The following is a description of a gene set: studied in species Homo sapiens from publication Wirth TC, Xue HH, Rai D, Sabel JT, Bair T, Harty JT, Badovinac VP (PMID 20619696) The transcriptome of naive OT-I T cells was compared to memory CD8 T cells after 1, 2, 3, or 4 infection with ovalbumin expressing Listeria monocytogenes (LM-OVA). Human Gene Set: GSE21360_PRIMARY_VS_QUATERNARY_MEMORY_CD8_TCELL_DN Genes down-regulated in memory CD8 T cells: 1' versus 4'., and this is the list of marker genes: DHRS1, TLE5, MORF4L1 (NCBI Gene Id 10933), BAHD1, BCL11B, ABLIM1, JADE2, SQSTM1, ERBIN, PIK3CA, IRF7, SERINC3, DCAF8, CCDC93, S100A10, ARL2BP, RPL37, IKBKB, ZNF83 (zinc finger protein 83, NCBI Gene Id 90328), LRP10, DOCK9, RSBN1, SNX3, BMAL1, TRIM14, SIRT3, ZNF14, CD96, SLC35E2A, CEP350, SNX6 (NCBI Gene Id 58533), NPFF, NDRG1, SENP6, PARP8, CCDC91, ARFGEF1, SORL1, KLF2, BAZ2A, BNIP3L, ALAD, STAG2, PPP6R3, MON2 (MON2 homolog, regulator of endosome-to-Golgi trafficking), RPS15A, TOP2B, SON, FAM149B1, CAPN2, SLC16A5, ATF2, WASF2, ENTPD4, OSBPL2, PRKCQ, BACH1, USPL1, LRCH4, SAMD9, ZNF862 (zinc finger protein 862), PNRC1, FAM117A, TAX1BP3, NCOR1, UBL3, PRKCZ, RIN3, FBXL5, EFCAB14, SYNJ2BP, ASAH1, S100A6, ST6GAL1, SMURF2, SSH3, PCF11 (NCBI Gene Id 51585), GALNT11, MST1, RC3H2, HSD17B3, RAB4B, TMEM63A, LIPT1, ARMC8, ASTE1, PLEKHO1, EPM2AIP1, MACF1, MZF1, ULK1, ZNF573, HPCAL4, CLCC1, DENND2D (NCBI Gene Id 79961), WDR44, VPS13B (vacuolar protein sorting 13 homolog B), SKAP1, ZFYVE16, KDM5A, TMED10, ATP6AP2, IFI44L, ZNF236, RBM26, TNK2, ZFAND6, TTC17, ZBED5, RXRB, USP11, C2orf68, GPRASP1, CCS, NME3, NGRN, ELANE, HIPK1 (homeodomain interacting protein kinase 1), TOR1B, ZC3H11A, STAT4, WDR45, CTBS, RASGRP1, CTDSP2, C6orf62, AGTPBP1, ZNF652, PSME3IP1, TDRD7, MCM3AP, WIPF2, SIGIRR, SNRK, ZC3HAV1, CREB1, ADD3, ZBTB22, TRAF5, PJA2, ABI1, KCNA3, CCDC69, CTDSP1, BICRAL, KLHDC10, LMF2, BBX, RUBCN, TGOLN2, CD247, CSRNP2, C2CD3, DPF2, PILRB, CD37, BRD1, FRAT1, DICER1, NBR1 (NCBI Gene Id 9740), PTTG1IP, SPG11, SARAF (NCBI Gene Id 95251), PPP1R12A, TRIOBP, WWP1, CMTR1, LTBP3, LEMD3, AKAP17A, VEZF1, CLEC2B, PPP2R5A, ZNF814, TSC22D3, TRIB2, TPP1, GCC2, SPTAN1, ARHGAP15, CELSR2, RIPOR2, ZNF302, CHD9, SHC1, LETMD1, TMEM80, SETD2, DET1, RYK, RPS29, MKRN1, LPIN1, FMR1, TCF20, AGBL2, CITED2, AKAP9